Given this list of marker genes PDK1 (pyruvate dehydrogenase kinase 1), GRHPR (glyoxylate and hydroxypyruvate reductase), FDX1 (ferredoxin 1), NRDC, CTTN, SIPA1L1, NKTR, DCAF7, CCT3 (NCBI Gene Id 7203), SUB1, SLK, ACACA (NCBI Gene Id 31), HSPA8, ERO1B, ZNF697, GPD2, SEC61B, PLP1, MED13, GCLM, BSG, ACSL1, CYP51A1, MED6, FGFR1, VMP1, PTGFRN, RALBP1, PSMC2, ZNF292, RASL11A, MAPKAPK3, LMOD3, PACSIN2, RPL22, DMAC2, TGFA, PAPSS2, SDC2, TFF2, CD200, LTBP2, MYC, OBP2B, RABGGTB, NR2F2, NUP98, FLT1, DNAJB9, EXOC8, MYL4, RAC1, EGF, SFPQ, FN1, OGT, CHD6, RABEP1, IL2, NUCB1, IQCJ-SCHIP1, SCG2, GATA6, TUBGCP4, MOSMO, ANKIB1 (ankyrin repeat and IBR domain containing 1), APMAP, TCF3, NR4A2, COPB1, AGTR1, CLCN7, MAX, AKT1, ITPR1, RPS6KB1, NAA20, MLST8, AHR, KBTBD3, CCNL1 (cyclin L1), CHGA, SERP1, SLC6A6, NCKAP1, MET, CNTF, CD3G, OLR1, HUWE1, CSNK1G2, HSPH1, INSIG1, MLLT10, CNN3, ATP6V1B2, NOLC1, DNM2, MAPK14, PLOD1, ABTB2, ARL10, CMTM6, PCM1, PET100, DIO2, ATP6V1D, SLCO1A2, SEL1L, EVI5, EGLN3, F13A1, HMGCS1, TPT1, GADD45A, STK38, VEGFA, MYBPC1, NUP58, COL11A1, CEBPG (NCBI Gene Id 1054), S100A10, ATP12A, HNMT, ACAT2, CTH, ASF1B, RNF4, MTDH, ST3GAL5, PTGS1 (prostaglandin-endoperoxide synthase 1), PSMC5 (proteasome 26S subunit, ATPase 5), PURB, PAK2, CDC42, MTCH2, ATP5PB, PITPNA, KIAA0040, MYCBP2, CEBPD, ACTN4, BHLHE40, IGFBP5, SLC4A4, PMP22, TRIM25, RB1, GPAM, PMCH, REXO2, C15orf62, H3C14, IGFBP6, SLC27A1, ITGB7, FMOD, USO1, GPC6, BOK, LYSMD3, VPS26A (NCBI Gene Id 96725), ZNF775, PDLIM4, KIF12, SKIC8, HMGCR, DPP4, ALDH3A2 (NCBI Gene Id 224), ST8SIA4, AFP, SNF8, BPIFB4, NRG1, DDOST, HIGD1A, POU3F1, DBI, VCAM1, HRH2, TMEM214, LDLR, NVL, MAP2K1, F2, TATDN2, PSMD4, JAK2, ALAS1, ATP7A, JAG1, EDN1, ARG1, TIMM23, ZEB1, DHODH, PPAT (NCBI Gene Id 5471), CIPC, BCL7B, IDE, SSR4, ACVR1, FHL2, SCD, SMARCA4, SCGB1D1, LAMA5, LBR, AMD1, PTPRJ, HRK, PSAT1, UGT1A10, MDH2, NMT1, HOOK1, COL5A1, NEO1, TRA2B, SERINC3, IVD, SLC25A3, APP, AP1S3, NPR3 (natriuretic peptide receptor 3), PPIB, SPTY2D1, AHNAK, SCUBE3, HADHB, SAMD4B, SART3, ELOB, STK39, JUP, NR2F6, KLF10, MAP2, PLAA, CST3, KIF11, SMAD1, SOAT1, RNF130, TNS3, C1R, GRIA2, LGALS8, NDUFB1, SMC1A, STX4, PFKFB2, CHP1, DUSP6, ARHGAP31, C18orf54 (NCBI Gene Id 162681), NDUFAB1, NUDT4, ADM, CASK, SMAD2, P4HA1, SCFD2, RPS12, MAGT1, LYST, C8B, MRPL40, VCF1, GNB1, TFRC, SLC12A4 (NCBI Gene Id 6560), NUPR1, NME1, PLEKHA7, TIMM10B, THOC2, CPQ, DYNC1LI2, YWHAZ, LSS, MYH2, AIMP2, LITAF, UQCC2, CDK7, NRBP1, CCL4, PGK1, MFN2, MPZL1, SND1, FLT3LG, NFIA, BDNF, GM2A, ACTB, HTT, PSAP (prosaposin), SLIT3, NF1, UBE2G1, ATP5PO, MAP2K6 (mitogen-activated protein kinase kinase 6), ABAT, GREM1, EIF2B5, TWF1, COPZ2, ATXN3, GPHN, SLC30A4, CKMT2, WFDC1, MAGI1, SLC16A1, EMC8, SEC62, IFT46, HLA-B, FRK, AMFR, TNKS2, EHMT2, TKFC, ODC1 (ornithine decarboxylase 1), SPON1, CACNA1A, NR1D2, VIPR2, BET1, PTPRM, NPTN, RPN2, EIF5, PRICKLE2, PHB1, PCDHGB5, FCGR2B, MSH2 (NCBI Gene Id 8169), PDPK1, ARL5A, FUCA1, HSPA9, SRSF3, MEOX2, RAPGEF3, LIPA, ADIPOR2, PNLIPRP2, SERBP1 (SERPINE1 mRNA binding protein 1), LEP, ANKFY1, MSMO1, PPIL3, EMP1, DNAJA2, CD5, PRUNE2, IL6, HSPA1A, ABRACL, TMED10, CHAMP1, PTPRA, TOR1AIP1, GOLGA1 (NCBI Gene Id 2800), BCLAF1, ALDOA, ROCK2, TOP2A, CD48, RNASE4, COX5A, TMBIM6, TIMP3, ANKRD24, CYB5B, SCFD1, KIF3C, PDGFRA, APLP2, AQP4, WDFY1, IL6ST, here is a description of the gene set: species: Rattus norvegicus Abdominal aortic aneurysm (AAA) is a common disease among elderly people that, when surgical treatment is inapplicable, results in progressive expansion and rupture of the aorta with high mortality. Although nonsurgical treatment for AAA is much awaited, few options are available because its molecular pathogenesis remains elusive. Here, we identify JNK as a proximal signaling molecule in the pathogenesis of AAA. Human AAA tissue showed a high level of phosphorylated JNK. We show that JNK programs a gene expression pattern in different cell types that cooperatively enhances the degradation of the extracellular matrix while suppressing biosynthetic enzymes of the extracellular matrix. Selective inhibition of JNK in vivo not only prevented the development of AAA but also caused regression of established AAA in two mouse models. Thus, JNK promotes abnormal extracellular matrix metabolism in the tissue of AAA and may represent a therapeutic target. Genes down-regulated in vascular smooth muscle cells (VSMC) by MAPK8 (JNK1). from publication Yoshimura K, Aoki H, Ikeda Y, Fujii K, Akiyama N, Furutani A, Hoshii Y, Tanaka N, Ricci R, Ishihara T, Esato K, Hamano K, Matsuzaki M (PMID 16311603) Human Gene Set: YOSHIMURA_MAPK8_TARGETS_DN